Given this list of marker genes SLC35C1, SOST, ODAD4, MAGT1, IL2RG, FGF3, CACNA1B, IMPDH1, CA2, IDS, EFTUD2, NSUN2, CD3G, MAPK1, RAG2, NCKAP1L, SDR9C7, KANSL1, ODAD1, DNAAF5, TULP1, FOXL1, DLG1, LRBA, IMPG2, GUCA1B, ARL2BP, TNFSF11, ADAT3, MCIDAS, REEP6, RHO, SMCHD1, PRKCD, ABCA4, IL7R, FOXP1, TBX1, NR2E3, TP63 (NCBI Gene Id 8860), BLNK, CD28, GP1BB, TELO2, FAT4, HEPHL1, RAI1, G6PC3, TCIRG1, NEK10, HNRNPK, LIG1, RFXAP, KIF1B, AGR2, SLC25A12, GNB2, ALX1, DNAAF4, FOXN1, SPAG1, MYH3, MEOX1, UBE4B, RAB23, SMG9, FSCN2, IKBKB, COBLL1, FANCF, AHDC1, IKBKG (inhibitor of nuclear factor kappa B kinase regulatory subunit gamma), ICOS, HLA-B, TMEM270, RSPH1, MAP3K7, SULT2B1, SF3B2, CYBA, HIRA, DNAH5, COL11A2, CC2D2A, HDAC4, LBR, LMNA, CD3D, BBIP1, SIN3A, POLR1D, ERCC6, BBS1, DNAAF1, BPTF, FGFR2, CNOT3, KAT6A, CTLA4, SPI1, LUZP1 (NCBI Gene Id 7798), PDPN, CEP290, ARHGEF18, EIF5A, FRAS1, ADA, MKS1, CPLANE1, PIK3CG, CD81, GMNN, CNGA1, ARL6, SEC61A1, DIAPH3, PGM3, FLNB, SDHB, GATA2, EDNRA, SLC7A14, USH2A, ZEB2, PRPF4, ADAMTS3, POMGNT1, NFKB2, WDR26, PTEN, MASP1, GNPTAB, POU3F4, BUD23, ELANE, ARL3, CFAP298, AIRE, GNS, RERE, DVL1, AFF4, USB1, IDH3A, DNAAF11, KMT5B, MEG3, ZNF513 (NCBI Gene Id 130557), BTK, EPAS1, STX1A, SLF2, CD19, AK2, KIAA0753, EXT1, LZTFL1, TP73, EYS, FANCI, CHD7, RNF168, RPE65, DHDDS, SMARCA4, SKI, GRIP1, SYK, CFAP45, CA4, CDH1, TNFSF12, DOCK8, DNMT3A, PIK3CD, UNC119, PRPF3, ACP5, COL1A2, NXN (nucleoredoxin), ERF, PRKCZ, HDAC8, RAG1, GTF2IRD2, OSTM1 (NCBI Gene Id 28962), CD79B, GJB2, VPS37D, FAM20C, ELN, MED12, CDHR1, CCDC47, GJB6, CREBBP, DCLRE1C, SRY, UFD1, CCDC40, ZNF699, FBXO11, RPS26 (ribosomal protein S26), NIPAL4, FH, KMT2D, CTBP1, OFD1, DDR2, ABCA12, FGF10, RAC2 (NCBI Gene Id 5880), KLHL7, CIITA, CASZ1, TMEM67, KCNAB2, BMP2, NBN, RSPH4A, PRPF8, SRCAP, MAN2B1, RUNX2, DNAH9, C1QB, AP3B1, TTC12, PDCD1, SETD2, APC2, NPHP1, TCF3, PDGFRA, NCF1, IGBP1, CBLB, LRRC56, H4C3, TNFRSF13B, CYBB, RREB1, FBXW7, TRPS1, OCRL, RAD21, DNAJC30, ADA2, KMT2A, FMR1, ZBTB20, KIAA1549, IFT140, ARHGEF38, STAG2, RAC1, FREM2, ERCC8, SAG, GTF2I, IFT27, CORO1A, DOCK2, IL11RA, SP7, SIX5, GALNT2, HSPG2, OTOF, CDK5RAP2, IL21R, CNGB1, HYDIN, RIC1, SNX10, CFAP221, TUB, ENPP1, DNAI1, ODAD2, SDHAF2, JMJD1C, TAF6, ZFX, ANKH (ANKH inorganic pyrophosphate transport regulator), TMEM231, COL11A1, CLCN7, EDN1, ARHGAP29, STAT3, ANAPC1, SMC1A, RECQL4, LRAT, DNAL1, CHRNG, RP2, HAX1, NCF2 (NCBI Gene Id 4688), BBS10, ZNF408, DCHS1, CNOT1, TAF4, DEAF1, DNAAF3 (dynein axonemal assembly factor 3), RSPH9, TLK2, MDH2, IGHM, FLII, BBS7, CYBC1, DNAH1, C4B, AGA, PRDM5, SNF8, NFKB1, RPGR, IGHG2, DPF2, GSC, PNP, LIPN, SPEN, CPLX1, NOTCH3, LETM1, TCOF1, SDHC, METTL27, NFIX, PIK3R1, TWIST1, FOXJ1, HLA-DPA1, ATN1, FGF9, MMP23B, RNF2, CYP4F22, SPATA7, RAP1B, SDHD, CARMIL2, PHIP, NELFA, TAP1, IGLL1, CD79A, IDH3B, HGSNAT, AIFM1, TOPORS, B3GLCT, POGZ, SH3KBP1, CFAP52, ROR2, HLA-DPB1, ALOXE3, BEST1, PRPH2, CLIP2, TBL2, BAP1, IL2RB (NCBI Gene Id 3602), ARID2, RP9, CXCR4, CFI, JAGN1, TFE3, POR, TCTN3, PLG, ZMYND10, SALL4, PIGH, PORCN, SLC25A24, PCGF2, SMC3, EYA4, TNFRSF11A, KIF15, GAS2L2, SETBP1, NFKBIA, COL1A1, BBS5, RGR (NCBI Gene Id 5995), P4HA2, IL6R, TFAP2A, FZD2, MAX, FBN1, PTPN22, STIM1, PCARE, EIF4H (NCBI Gene Id 94573), SGMS2 (NCBI Gene Id 166929), TSHZ1, WAS, PRKAR1B, CERKL, IL17RA, PLCG2, PRRX1, ARSL, CD4, PIGG, PDE6G (phosphodiesterase 6G), RELB, NIPBL, TRAC, DRC1, RNU4ATAC, COG1 (component of oligomeric golgi complex 1), MS4A1, RPS23, GRHL3, COL2A1, FAM149B1, ACVR1, PIK3C2A, ALOX12B, TBX22, MNS1, NOG, DPP9, CCDC39, RTL1, RPL11, LRRC8A, RNU4-2, NAA10, ELMOD3, PIGL, EP300, RFX5, SCAPER, CEP19, NOTCH2NLC, HLA-DRB1, DNAAF2, CCDC65 (coiled-coil domain containing 65), DDB1, SH2B1, TLR8, DYRK1A, BBS4, IQSEC2 (NCBI Gene Id 4382), PROM1, ICOSLG, BCOR, TMCO1, WIPF1, TTC8, TRIM32, VHL, BBS9, DNAJB13, IRF6 (interferon regulatory factor 6), SMARCD2, POLR1A (NCBI Gene Id 90784), BMP4, DNAH11, CTNND1, DHCR7, NEK1, BBS12, CDCA7 (NCBI Gene Id 83879), TGDS, TXNL4A, IFT88, RDH12, LIG4, PCYT1A, WDPCP, MLXIPL, MYCN, CLRN1, UBB, MERTK, ALX3, HYAL1, GAS8, PRCD, TNFRSF13C, MKKS, PAX1, FGFRL1, KIZ, NME8, TGM1, ODAD3, TMEM216, SDCCAG8, IRF2BP2 (NCBI Gene Id 359948), DNAAF6, PRPF31, A2ML1, TAF1, KIF7, SHARPIN (SHANK associated RH domain interactor), POLR1C, CD247, NSD2, SPTBN1, RPS28, AHI1, FOCAD, SIX1, ASPRV1, LRP5, SLC25A11, BLM, IL6ST, ELMO2, CDC42BPB, PGM1, STAC3, FCGR3A, PRPF6, AMER1, PDE6A, SCLT1, CCDC103, RBP3, ABCC6, CEBPE, KDM6A, RP1L1, GUSB, H4C5, ALMS1, IFT172, USP26, PSMD12, DNAI2, RP1, TSR2, RLBP1, NOTCH2, EYA1, SLC37A4, BRD4, PEPD, NME5 (NCBI Gene Id 8382), PRTN3, PSMB8, IFT74, CRX, SOX9, DHODH, BAZ1B, FAM161A, INSR, RFXANK, ARVCF, RFC2, PDE6D, ROM1, ZNF341, MAK, PRDM16, SEC24C, DHX38, CDH11, GLRA2, LIMK1, AGBL5, SNRPB, TBX4, GABRD, GDF6, JAK3, NSD1, ANKRD11, BBS2, GJA1, AMMECR1, IDUA, RET (NCBI Gene Id 5979), CFAP74, CRB1, POLR3A, ZNF469, VARS1, MPDU1, DAW1, SDHA, IMPG1, TAOK1, RSPH3, NEK2, HOXA2, SLC39A7, FLNA, DOCK11, CCBE1, POLR1B, MGP, CFAP418, DLST, FGFR3, ROBO1, NRL, B3GALT6, DLX4, NECTIN1, DLK1, CR2, CCNO, GTF2IRD1, CD3E, ZMPSTE24, PDE6B, FKBP6, PRORP, LONP1 (NCBI Gene Id 9361), NKX2-1, STK36, TPP2, NF1, MSX1, CTSK, THRB, FKBP14, TNRC6B (trinucleotide repeat containing adaptor 6B), COMT (catechol-O-methyltransferase), TMEM127, CFAP300, SF3B4, SEMA4A (semaphorin 4A), NCF4, SPEF2 (NCBI Gene Id 80192), GDF5, AHR, IGKC, SNRNP200, CREB3L1, here is a description of the gene set: Human Gene Set: HP_ABNORMALITY_OF_THE_MIDDLE_EAR Abnormality of the middle ear studied in species Homo sapiens An abnormality of the middle ear.